Given this list of marker genes Wnt7a, Kif14, Dixdc1, Comt, Ogdh, Serpine2, Fktn, Lhx1, Aars1, Dll1, Atxn2, Atp7a, Pcnt, Uqcrq, B4galt2, Ophn1, Sez6l, Map2k1 (NCBI Gene Id 26395), Ttll1, Coq8b, Nrxn1, Gli1, Zfp365, Clp1, Hspa5, Mdk, Cbln1, Usp9x, Faim2, Gba1, Psap, Ulk1, Cdk5, Slc25a46, Cend1, Tuba1a, Trnp1, Ptpn11, Ttc21b, Smo, Naglu (alpha-N-acetylglucosaminidase (Sanfilippo disease IIIB)), Ttbk2, Sez6, Whrn, Ezh2, Agtpbp1, Myh10, Herc1, Klhl1, Atg7, Rora, Grid2, Sez6l2, Cntnap2, Agtr2 (NCBI Gene Id 11609, angiotensin II receptor, type 2), Pantr2, Atp2b2, Prox1, Rere, Foxp2, Arcn1, Skor2, Ldb1, Sptbn2, Kndc1, Lhx5, Mtpn, Gli2, Neurod2, Nfix, Cacna1a, here is a description of the gene set: Mouse Gene Set: GOBP_CEREBELLAR_CORTEX_DEVELOPMENT species: Mus musculus The process whose specific outcome is the progression of the cerebellar cortex over time, from its formation to the mature structure. The cerebellar cortex is a thin mantle of gray matter that covers the surface of each cerebral hemisphere. It has a characteristic morphology with convolutions (gyri) and crevices (sulci) that have specific functions. Six layers of nerve cells and the nerve pathways that connect them comprise the cerebellar cortex. Together, these regions are responsible for the processes of conscious thought, perception, emotion and memory as well as advanced motor function.